The following is a description of a gene set: part of: Metal ion SLC transporters Zinc is an essential element for all organisms because it serves as a catalytic or structural cofactor for many different proteins. Cellular zinc homoeostasis is co-ordinated through Zn2+-specific transporters which are members of two distinct gene families. Members of the SLC39 gene family (ZRTL-like import proteins1-14, ZIP1-14) are responsible for Zn2+ import into the cytoplasm, either across the plasma membrane or out of intracellular organelles. In contrast, members of the SLC30 gene family (zinc transporters 1-10, ZnT1-10) export Zn2+ from the cytoplasm, either across the plasma membrane into the extracellular space or into intracellular organelles (Murakami M and Hirano T, 2008; Devirgiliis C et al, 2007; Eide DJ, 2006). Reactome Pathway: Zinc transporters species: Homo sapiens, and this is the list of marker genes: SLC30A1, SLC39A8, SLC30A2, SLC39A1, SLC30A3 (solute carrier family 30 member 3), SLC39A3, SLC39A10, SLC30A8, SLC39A5, SLC39A2, SLC39A14, SLC39A4, SLC39A6, SLC30A5, SLC39A7